The following is a description of a gene set: The removal of a glutamate residue from a protein. Glutamate residues in proteins can be gene-encoded, or added as side chains during the protein modification process of polyglutamylation. Mouse Gene Set: GOBP_PROTEIN_DEGLUTAMYLATION studied in species Mus musculus, and this is the list of marker genes: Agbl4, Agbl1, Agtpbp1, Agbl2, Agbl3, Agbl5